Given this list of marker genes PNMT, MED1, PGAP3, CDK12 (cyclin dependent kinase 12), GRB7, GSDMB (NCBI Gene Id 55876), ERBB2, here is a description of the gene set: Cluster 8: selected ERBB2 amplicon genes clustered together across breast cancer samples. Human Gene Set: FARMER_BREAST_CANCER_CLUSTER_8 from publication Farmer P, Bonnefoi H, Becette V, Tubiana-Hulin M, Fumoleau P, Larsimont D, Macgrogan G, Bergh J, Cameron D, Goldstein D, Duss S, Nicoulaz AL, Brisken C, Fiche M, Delorenzi M, Iggo R (PMID 15897907) Previous microarray studies on breast cancer identified multiple tumour classes, of which the most prominent, named luminal and basal, differ in expression of the oestrogen receptor alpha gene (ER). We report here the identification of a group of breast tumours with increased androgen signalling and a 'molecular apocrine' gene expression profile. Tumour samples from 49 patients with large operable or locally advanced breast cancers were tested on Affymetrix U133A gene expression microarrays. Principal components analysis and hierarchical clustering split the tumours into three groups: basal, luminal and a group we call molecular apocrine. All of the molecular apocrine tumours have strong apocrine features on histological examination (P=0.0002). The molecular apocrine group is androgen receptor (AR) positive and contains all of the ER-negative tumours outside the basal group. Kolmogorov-Smirnov testing indicates that oestrogen signalling is most active in the luminal group, and androgen signalling is most active in the molecular apocrine group. ERBB2 amplification is commoner in the molecular apocrine than the other groups. Genes that best split the three groups were identified by Wilcoxon test. Correlation of the average expression profile of these genes in our data with the expression profile of individual tumours in four published breast cancer studies suggest that molecular apocrine tumours represent 8-14% of tumours in these studies. Our data show that it is possible with microarray data to divide mammary tumour cells into three groups based on steroid receptor activity: luminal (ER+ AR+), basal (ER- AR-) and molecular apocrine (ER- AR+). species: Homo sapiens